The following is a description of a gene set: species: Mus musculus Mouse Gene Set: GOBP_NEGATIVE_REGULATION_OF_NEUTROPHIL_ACTIVATION Any process that stops, prevents or reduces the frequency, rate or extent of neutrophil activation., and this is the list of marker genes: Ptpn11, Cd300a, Ptpn6, Src, Clec12a (NCBI Gene Id 232413), Grn